The following is a description of a gene set: from publication Chiang DY, Villanueva A, Hoshida Y, Peix J, Newell P, Minguez B, LeBlanc AC, Donovan DJ, Thung SN, Solé M, Tovar V, Alsinet C, Ramos AH, Barretina J, Roayaie S, Schwartz M, Waxman S, Bruix J, Mazzaferro V, Ligon AH, Najfeld V, Friedman SL, Sellers WR, Meyerson M, Llovet JM (PMID 18701503) Hepatocellular carcinomas represent the third leading cause of cancer-related deaths worldwide. The vast majority of cases arise in the context of chronic liver injury due to hepatitis B virus or hepatitis C virus infection. To identify genetic mechanisms of hepatocarcinogenesis, we characterized copy number alterations and gene expression profiles from the same set of tumors associated with hepatitis C virus. Most tumors harbored 1q gain, 8q gain, or 8p loss, with occasional alterations in 13 additional chromosome arms. In addition to amplifications at 11q13 in 6 of 103 tumors, 4 tumors harbored focal gains at 6p21 incorporating vascular endothelial growth factor A (VEGFA). Fluorescence in situ hybridization on an independent validation set of 210 tumors found 6p21 high-level gains in 14 tumors, as well as 2 tumors with 6p21 amplifications. Strikingly, this locus overlapped with copy gains in 4 of 371 lung adenocarcinomas. Overexpression of VEGFA via 6p21 gain in hepatocellular carcinomas suggested a novel, non-cell-autonomous mechanism of oncogene activation. Hierarchical clustering of gene expression among 91 of these tumors identified five classes, including CTNNB1, proliferation, IFN-related, a novel class defined by polysomy of chromosome 7, and an unannotated class. These class labels were further supported by molecular data; mutations in CTNNB1 were enriched in the CTNNB1 class, whereas insulin-like growth factor I receptor and RPS6 phosphorylation were enriched in the proliferation class. The enrichment of signaling pathway alterations in gene expression classes provides insights on hepatocellular carcinoma pathogenesis. Furthermore, the prevalence of VEGFA high-level gains in multiple tumor types suggests indications for clinical trials of antiangiogenic therapies. species: Homo sapiens Human Gene Set: CHIANG_LIVER_CANCER_SUBCLASS_INTERFERON_UP All marker genes up-regulated in the 'interferon' subclass of hepatocellular carcinoma (HCC)., and this is the list of marker genes: EVI2A, ACSL4, SLC12A2, KMO, APOF, NNMT, STAT1, ISG15, ALOX5AP, MS4A4A, KCNT2 (potassium sodium-activated channel subfamily T member 2), KLRB1, SLC38A4, IFI27, IFI6, FCGR3A, PLA2G2A, FCGR2B (NCBI Gene Id 2213), TDO2, HPGD, GOT1, CALCRL, SERPINA7, GPR65, PRAMEF10, MOXD1